The following is a description of a gene set: species: Mus musculus The covalent attachment of sialic acid to a substrate molecule. Mouse Gene Set: GOBP_SIALYLATION, and this is the list of marker genes: St6gal1, St6galnac2, St8sia3 (ST8 alpha-N-acetyl-neuraminide alpha-2,8-sialyltransferase 3), St6gal2, St3gal2, St3gal1, 6430550D23Rik, St3gal4, St8sia4, St8sia2